Given this list of marker genes BUB1, CHMP4B (charged multivesicular body protein 4B), MLC1, RPA1, MKRN3, MBD1, AKR1D1, NISCH, PTGER4, NFKBIA, COL9A3, BCAS2, RNF25 (NCBI Gene Id 79103), ZNF518B, GNAT2, HTR3B, OAT, ZBTB2, IER2, TNFAIP2, CNNM3, BAG3, DOC2B, CCDC120, SRF (NCBI Gene Id 6722), ADGRE5, NLRP3, GZMK, LYPLA2, SYVN1, SLC39A11, GAP43, RIMKLB, CHERP, CRAMP1, CHPF, GPC1, MED26, WASF2, GDI1, MAP4K4, ATXN2, DDX59, PER1, BAG4, POLDIP3, CWC22, GIT1, DPYSL2, IER5, EPB41L1, TNPO2, KIAA0930, FZD2, CBX6, ASB15, HTR3A, IL2, FBXW9, WASL, HGS, NELFB, ZNF326 (NCBI Gene Id 64842), CSAD, TRIM27, FN1, TMEM131, RWDD2B, CARD19, HNRNPC, MPG, EHBP1, WDFY1, LRBA, TMEM63A, SMIM19, TESMIN, ARF3, FBXO31, TTC5 (tetratricopeptide repeat domain 5), PPT2, INPP5K, CA6, RBM14, RNF187, CCNK, JARID2, EIF4G1, ZNF219, ARHGAP35, IKBKB, AFF1, FRMD5, SUFU, MYO18A, PANX1, GDAP1L1, PTGR1, MLXIPL (MLX interacting protein like), COL7A1, CEBPB (CCAAT enhancer binding protein beta), NEK9, TBL2, TCEAL1, DENND4B, DOCK5, TMOD2, MIDN, NCOR1, DPF2, NT5DC3, BRD2, BLTP3A, MINDY3, HOXD3, FGFR3, ASPN, MARK4, TEC, TFPI2 (tissue factor pathway inhibitor 2), GLUL (NCBI Gene Id 2752), RBP7, STX6, POLRMT, CLCNKA, ZEB1, RPS6KA2, INCENP, ATP6V1C1, ZNF426, STT3B, EEF1G, MYADM, KIAA2013, SLC7A3, CISH, DIPK1B, MAN2C1, MAGIX, ZBTB21, IFRD2, MAGEE1, SLC18A1, MECP2, HSPB8, NPTX1, PIM1, XPO7, ASIP, GPT2, RECQL5, HSPB2, SHFL, HNRNPD, RC3H2, RNF149, SLC20A1, ATOSB, TRPC1, MTSS1 (MTSS I-BAR domain containing 1), HOXA11, MAML1, CDKN1A, GGCX, TRAF3, COX8A, OLIG2, ADCY9, HERPUD2, SOX13, ATP7A, ARHGDIA, GPR85, PHC2, CEP20, TMEFF1, TRA2A, MTHFD1, KIAA0319L, KCNK13, CEACAM21, GALC, MANSC1, CLBA1, ARHGAP23, COL4A6, CNR1, RHBDL3, ADAMTS5, LRRC14, SFT2D1, PGGHG, LLGL1, TPP1, GNPDA1, EYA3 (NCBI Gene Id 2140), PEX26, CAMSAP1, ADAM19, TSG101, here is a description of the gene set: Genes up-regulated in comparison of dendritic cells (DC) stimulated with Pam3Csk4 (TLR1/2 agonist) at 0.5 h versus DC cells stimulated with CpG DNA (TLR9 agonist) at 0.5 h. from publication Amit I, Garber M, Chevrier N, Leite AP, Donner Y, Eisenhaure T, Guttman M, Grenier JK, Li W, Zuk O, Schubert LA, Birditt B, Shay T, Goren A, Zhang X, Smith Z, Deering R, McDonald RC, Cabili M, Bernstein BE, Rinn JL, Meissner A, Root DE, Hacohen N, Regev A (PMID 19729616) Human Gene Set: GSE17721_PAM3CSK4_VS_CPG_0.5H_BMDC_UP studied in species Homo sapiens mouse primary BMDCs were stimulated with tlr ligands and gene expression changes were profiled on Affymetrix arrays